The following is a description of a gene set: Human Gene Set: OLF1_01 Genes having at least one occurrence of the motif NNCDABTCCCYAGRGARBNKGN in the regions spanning 4 kb centered on their transcription starting sites. This matches the OLF1, OR5I1 transcription factor binding site V$OLF1_01 (v7.4 TRANSFAC). studied in species Homo sapiens, and this is the list of marker genes: HOXD11 (homeobox D11), CNTNAP4, CD79B, CD79A, SLC17A6, ATP2B3, GRM7, C2orf69, MLLT6, PCYT2, SEMA3B, NLGN3, ENTPD7, ASCL2, NUFIP2, TNS2, HES7, CCKBR, PTPN21, NEUROD2, UBTF, PPP2R2A, RND2, KCNQ5, UPF2, WSB2, VCL, CTTNBP2NL, PPTC7, CYP46A1, BEX2, NUDT4, FGF12, HOXD13, REEP6, RABL3, TNFSF13, DLG3, PRKCG, TBXAS1, CMKLR1, CRLF1, MIB2, PLPPR1, MACROH2A2, NR1D1, CA14, ZC3H18, RGS3, SMPD3, TLK2 (tousled like kinase 2), AFF3, PITPNM2, ARHGAP44, ROBO3, RAB6A, PDGFRB, CDX1, BUD23, MS4A1, VWA5B1, TTC9C, CDK9, UBA1, PTMS, HOXA6, EGR1, FAM53C, ALDOC, COL23A1, SCUBE3, PTPN6, HID1, PCBP4, FRMPD1, RANGRF, KCND1, R3HDM1, ELK3, CACNA1E, MORC3, SORBS2, RYBP, SDK1, KAT5, LIX1L, KCNJ2, HS3ST4, AKT2, IGSF1, SOX5, GRIK1, TCF21, GTPBP2, TRPS1, HOXD4, UBE2N (NCBI Gene Id 7334), GSTM5, PPFIA2, ERCC2, TMEM59L, EPHB6, PPP3CB, ANGPT4, REM2, CA7, PTCH1, IRAG1, CREB3L1, ZSCAN20, ITPR2, ZBTB7A, C19orf73, ZNF428, ART4 (NCBI Gene Id 420), BARHL1 (BarH like homeobox 1), DYRK2, SNN, PTHLH, SGK1, DPYSL5, SOWAHA, BCLAF3, OMP, JARID2, HPSE2, GSK3B (glycogen synthase kinase 3 beta), PRKCH, SYT6, ATP5MK, KCNQ1DN, KMT2E (NCBI Gene Id 84147), LIMK2 (NCBI Gene Id 3985), MAP1LC3A, GRIN2D, TFAP2C, MAP1B, FAM217B, RNF220, DCX, RAVER1, MAG, ZBTB37, ADRA2B, POLK, GATA1, ZEB2, ZNF8 (NCBI Gene Id 7554), NEO1, ENTPD1, FGF11, FXR2, ACY1, IL11, COL11A2, GNB3, YWHAG, KLC4, GALNT7, KDM3B, SLC6A9, ADCY6, GAS6, VGF, SEMA3G, DNAJC30, RBBP6, ERO1B, ZNF711, H3-3B, ZNF410, DUSP3, SIAH3, HOXC13, OLIG1, FLT1, TLNRD1, ALKBH6, UBE2W, HACE1 (HECT domain and ankyrin repeat containing E3 ubiquitin protein ligase 1), SLC38A9, TLCD4, OLFML3, NEUROG3, RAI1, RPS6KB1, ODF1, JUP, ELAVL3, PRMT1 (protein arginine methyltransferase 1), WBP2NL, GTF3C2, MYO19, GON7, SALL2, IPO7, TSC22D4, TMEM229B, C1QTNF9, SLC41A1, DCTN3, PPRC1, STOML3, CMTM8, CYRIA, IRF2BP1, TBC1D31, MYCL, ABHD2, FBXL19-AS1, GABARAPL2, NFATC4, FXYD2, NF1, NCOA2, ESRRG, NOG, ATP1A2, RAB2B, STIM2, C2CD2L, MECOM, TPM1, MEIS2, BMP4, SP7, SZRD1, DDX17, TMEM187, FAM117A, CD19, KLK9, TYR, PPFIA3, GHR (NCBI Gene Id 2690), SHF, MMP15, FGF8, FADS3, EXD1, ALOX12B, CCNJL, ELF5, MRPL2, SRSF2, TIGD2 (NCBI Gene Id 166815), PCGF1, SPIB, CCN1, CLEC18C, MAGED2, SPATC1L, PPP1R3D, UBR7, KIF5B, RLBP1 (retinaldehyde binding protein 1), TBX21, GRWD1, GFRA1, GPR61, TRMT10A, SLC13A4, CAPN6, EPC1, LRRN3, AIFM3, RELT, PIGW, SCN4B, ZBTB9, MMP1, PSD, KDM2A, CERT1, SETMAR